Given this list of marker genes AAAS, SMARCB1, AKT1, GLI2, NR0B1, TERT, ARMC5, STAR, PRKAR1A (NCBI Gene Id 5573), TP53, PDGFB, AIP, NF2, FOXA2, NNT, OTX2, CYP11A1, POR, ROBO1, CDH23, TXNRD2, LHX4, SOX3 (NCBI Gene Id 8256), TRAF7, SUFU, NFKB2, BRAF, PIK3CA, PDE11A, TRAPPC11, BAP1, NR3C1, SMO, POU1F1, HESX1, CYP11B1 (cytochrome P450 family 11 subfamily B member 1), USP8, ATRX, MEN1, PROP1, MC2R, GMPPA, USP48, MRAP, SMARCE1 (SWI/SNF related, matrix associated, actin dependent regulator of chromatin, subfamily e, member 1), KDM1A, LHX3, GNAS, here is a description of the gene set: Human Gene Set: HP_ABNORMAL_CIRCULATING_ADRENOCORTICOTROPIN_CONCENTRATION species: Homo sapiens Abnormal circulating adrenocorticotropin concentration An abnormal concentration of corticotropin in the blood.